The following is a description of a gene set: Human Gene Set: GSE2770_IL12_AND_TGFB_ACT_VS_ACT_CD4_TCELL_48H_UP species: Homo sapiens Genes up-regulated in CD4 T cells activated by anti-CD3 and anti-CD28: TGFB1 and IL-12 (48h) versus untreated (48h). from publication Lund R, Aittokallio T, Nevalainen O, Lahesmaa R (PMID 14607935) Th1 and Th2 cells arise from a common precursor cell in response to triggering through the TCR and cytokine receptors for IL-12 or IL-4. This leads to activation of complex signaling pathways, which are not known in detail. Disturbances in the balance between type 1 and type 2 responses can lead to certain immune-mediated diseases. Thus, it is important to understand how Th1 and Th2 cells are generated. To clarify the mechanisms as to how IL-12 and IL-4 induce Th1 and Th2 differentiation and how TGF-beta can inhibit this process, we have used oligonucleotide arrays to examine the early polarization of Th1 and Th2 cells in the presence and absence of TGF-beta after 0, 2, 6 and 48 hours of polarization., and this is the list of marker genes: LINC01278, UBE2T, CUL4A, IL17RB, MTMR14, CUTC, GFUS, ZNF664, CAMK1D, MS4A4A, ALAS1, RHOF, NUBP1, SCD, TMEM161B-DT, TRMT61B, SCARB1, ANKMY2, EEPD1, NFXL1, RREB1, CEP85L, SYNGR2, DCXR, MRGPRX1, MCCC1, ALDOA, LINC01785, C1QB, S100P, TRMT13, THADA, ZNF876P, IL10RB-DT, CCL17, TXN, SYT17, CD46, PES1, UPK1B, PHOSPHO2, ACVR2A, ZNF682, ENSA, PRPF8, ALOX15, APOO, FCER2, MAEL, PLOD1, KDM2B, EHF, ZNF311, PLA1A, COMMD10, DHFRP3, IFNAR2, ENSG00000281732, INTS7 (integrator complex subunit 7), ST7-OT4, SNRPB, EEF2K, NEURL4, GGTA1, HSD11B1, RAB42, FADS1, EPHX1, ZBTB46, PIEZO1, PHPT1, SENP3, FADS2, COMMD1, TBXAS1, DCPS, SLA, SLCO3A1, C3orf18, AKR1B1, FABP4, HNRNPC, PCED1B-AS1, INF2, ZFP36L1, CWH43, STAB1 (stabilin 1), IDE, TMEM53, SDC4, ZNF569, SLC47A1 (solute carrier family 47 member 1), NUDT16L2P, BLTP2, GSDMD, FBXL17, REEP5, CFAP97, ACOX3, EMB, TADA1, SMARCC1, MAT2B, NUTF2, VPS50, CPT1A, EIF4G1, MAPK1, PDGFC, SCAND2P, SART1, IL18R1, IMPACT, HSP90AB1, COX10, KCNE1, ADRM1, CCL26, GSTP1, MRPL2, MFHAS1, ZC3H3, FLVCR2, BCL2L14, STOML2, ATAD3A, NUP93, RPAP3, DAXX, PPFIBP2, MTHFD1, C17orf58, MAGOHB (NCBI Gene Id 55110), GATA3, PPP1R9B, CHRNB4, PKD2, CCL22, PLIN2, PITRM1, SFT2D2 (NCBI Gene Id 92336), MAF, KISS1R, CCL5, PALLD, ETV6, SPINT2, ACSM5, SRCAP, MREG, TRIB2, NISCH, IGHG1, CLEC4G, TP53, SPHKAP, TMEM135, UQCC2, PPP1R15B, NANP (NCBI Gene Id 200269), REEP4, SNX17 (sorting nexin 17), MLST8, PSMD3 (NCBI Gene Id 94019), NCK2, MAOA, ENO1, UBTF, ACADVL, SORBS3, OXA1L, ARL4C, RIOK2, CHST7, SNAPC4, MMAB (NCBI Gene Id 89909), CD209, GPI, ECH1, TSPYL5, PRPS1, RMDN3, CFHR4, CLCA2, GAS2L3, ASAH2B, TKT, LHFPL6, PTGER2, TMA16, DPYS, C1QC, APOL6, RNASE1, TRAF1, TYW3, TTC9C, COQ5, ARHGAP25